Given this list of marker genes PYCR1 (NCBI Gene Id 5831), MBTPS2, REXO5, TXLNA, MKLN1, FABP5, NFIL3, TRAF1, FANCI, ALDOC, IL18RAP, TXN2, H4C3, IL2, UBE2S, BAG2, TWF2, PRDX1, TTK, NIT1, TK1, MAP2K3, GPI, EIF4EBP1, KIFC1, SMC2, IMPDH2, RAD51D, BCAT2, HSD17B10, NME1 (NCBI Gene Id 7794), SNAPC3, VDAC1, EEF1E1, SERPINE2, FRMD4B, MATR3, ENO2, ALDOA, S100A11, SORD, CDK2AP1, MCM2, HMMR, RRM2, BCAT1, KIF2C, PGK1, RAB13, SLC29A1, PNP, AHCYL1, SIT1, CDC45, HSPD1, PTTG1, LAG3, CKS2, GBE1, ATOX1, NCKIPSD, PRDX3, CCNB1, ARHGAP19, XPOT, COMT, AHCY, BHLHE40, GNPAT, IGFBP2, MYBL2, CDC6, SCD, BUB1B, NPM3, HSP90AB1, FARSA, SLC27A2, DHX16, CFI (complement factor I), NKG7, CKS1B, TP53 (tumor protein p53), MTHFD2, PCLAF, TTF2 (NCBI Gene Id 8458), SYT11, STAMBP, EED, RTL8C, TUBG1, CCNA2, SLC16A2, EIF2S1, PCYT1A, HMGCS1, COX6A1, SHMT2, PSMA6, NDUFA7, MAT2A, TYMS, ZBTB7B, THOP1, CDC7, TIAM1, HMGCL, CDT1, MRE11, EZH2, DHFR, MFSD10 (NCBI Gene Id 10227), VDAC3, GALK1, CCNB2, POLE2, CYB5B, SAP30, GK, CST7, PDXK (pyridoxal kinase), TEAD4, RUVBL2, TIMELESS, AARS1, RAB27A, PKM, TPI1 (triosephosphate isomerase 1), ATF1, SRM, ESPL1, MICAL2 (NCBI Gene Id 9645), PAICS, CDK1, AURKA, NDC80, GSTP1, PHGDH, ILK, NEK2, GNG5 (G protein subunit gamma 5), GZMH, CCT5, EBNA1BP2, MAST2, CCND2, CENPF, ACOT7, COX8A, MTHFD1, SYP, MIF, TNFRSF4, KIF11, MCM4, CTNNA1, TACR3 (tachykinin receptor 3), TUBA1B, RFC3, TRPC6, STX11, GATC, RAD51AP1, PCK2, DHCR7, TMEM106C, UBE2M, FAM161A (FAM161 centrosomal protein A), CFLAR, CLIC1, MCM3, PSMG1, AVPR1A, BDH1, ECI1, NCAPD2, PRIM1, GPX1, PDIA5, IGFBP4, TOP2A, VLDLR (very low density lipoprotein receptor), CDKN3, CDK4, GLA, HAX1, ENO1, LDHA, ASNS, GALK2, POLD2, KIF3B, RPA3, CENPS, PSMB9, MUC1 (NCBI Gene Id 4582), TPX2 (TPX2 microtubule nucleation factor), TOMM40, NCAPH, TNFRSF9, here is a description of the gene set: from publication Constantinides MG, Picard D, Savage AK, Bendelac A (PMID 21632718) species: Homo sapiens Human Gene Set: GSE28726_NAIVE_CD4_TCELL_VS_NAIVE_VA24NEG_NKTCELL_UP Microarray analysis was performed to determine the transcriptional profiles of NKT, CD1d-aGC+ Va24-, and CD4 T cells. Genes up-regulated in naïve T cells: CD4 versus Va24- NKT.